Given this list of marker genes MIF, SIRT1, BCL2L12, TAF9, CD44, BCL2, ZNF385A, ING2, TRIAP1, MARCHF7, TAF9B (TATA-box binding protein associated factor 9b), ELL3, MUC1, CD74, ATAD5, KDM1A, here is a description of the gene set: Any process that stops, prevents or reduces the frequency, rate or extent of intrinsic apoptotic signaling pathway in response to DNA damage by p53 class mediator. studied in species Homo sapiens Human Gene Set: GOBP_NEGATIVE_REGULATION_OF_INTRINSIC_APOPTOTIC_SIGNALING_PATHWAY_IN_RESPONSE_TO_DNA_DAMAGE_BY_P53_CLASS_MEDIATOR